The following is a description of a gene set: electronically inferred by orthology from the curated human pathway This event has been computationally inferred from an event that has been demonstrated in another species.<p>The inference is based on the homology mapping from PANTHER. Briefly, reactions for which all involved PhysicalEntities (in input, output and catalyst) have a mapped orthologue/paralogue (for complexes at least 75% of components must have a mapping) are inferred to the other species. part of: Transcriptional regulation by RUNX2 Reactome Pathway: Regulation of RUNX2 expression and activity studied in species Mus musculus, and this is the list of marker genes: Cul1, Psmb6, Psmd12, Psmb7, Psmd1, Ubb, Psmb4, Psma5, Rps27a, Psmd7, Runx2, Psmd13 (proteasome (prosome, macropain) 26S subunit, non-ATPase, 13), Psmc5, Psmc1, Psmc3, Psma2, Psma1, Psma6, Psmb5, Psmd6, Psma4, Psmc2, Psma3, Psma7, Psmc6, Psmc4